The following is a description of a gene set: Tryptophan metabolism Mouse Gene Set: WP_TRYPTOPHAN_METABOLISM studied in species Mus musculus, and this is the list of marker genes: Cyp1a2, Cyp2e1, Cyp2c55 (cytochrome P450, family 2, subfamily c, polypeptide 55), Acat1, Asmt, Aanat, Cyp1a1, Haao, Prmt1, Tdo2, Wars1, Ddc, Cyp19a1, Aadat, Hsd17b10, Dhcr24, Ido1 (NCBI Gene Id 15930), Hadh, Cyp1b1, Ube3a, Afmid, Ogdh, Ubr5, Cat, Gcdh, Tph1, Aox1, Aldh1a2, Inmt, Aldh1a1, Echs1, Cyp4f14, Acmsd, Rnf25, Cyp2j6, Kynu, Aldh2, Mdm2, Aldh3a2, Cyp2f2, Aoc1, Maob (NCBI Gene Id 236712), Aldh9a1, Cyp7b1